The following is a description of a gene set: Genes predicted to be targets of miRBase v22 microRNA mmu_miR_7659_3p in miRDB v6.0 with MirTarget v4 prediction scores > 80 (high confidence targets). from publication Chen Y, Wang X (PMID 31504780) studied in species Mus musculus Mouse Gene Set: MIR_7659_3P, and this is the list of marker genes: Pitpnm2, Fosb, Jup, Atp4a, Zfp462, Fkbp14, Triqk (triple QxxK/R motif containing), Tgfbr3, Fndc4, Neo1, Arf4, Trp53bp2, Btn1a1 (NCBI Gene Id 12231), Ric1, Gtf3c4, Slc9a9, Akirin1, Itfg1, G6pc1, Slc24a2, Eda, Cpt1a, Ntng1, Slitrk1, Zkscan8, Zfp319, Colec10, Dnajc9, Dnajb11, Ntmt1, Usp49, Kdm4b, Syt6, Crebrf, Atp1b4, Prelid3b, Rasl11b, Cntn3, Calb1, Dnm2, Nptx2, Atp2b4, Pdgfb, Zc3h13, Ppfibp1, Nr3c1, Hoxc5, Or8d4, Insig1, Ceacam1